Given this list of marker genes LGALS13, TGFB1, GPC1, PI3, IFNA17, P3H1, SFRP2 (NCBI Gene Id 6423), FGF22, WIF1, SERPINA5 (NCBI Gene Id 95024), SEMA6D, ADAM17, CLEC1A, SERPINB6, ADAM19, C1QL1, IL4, ANGPT2, BMP1, HBEGF, SERPINA11, ANXA6, LGALS9, FGFBP1, IL1F10, CTSS, CLEC1B, P4HA3 (prolyl 4-hydroxylase subunit alpha 3), C1QTNF3, IL1A, ELFN1, MMP3, P3H2, SERPINI2, IFNA10, SEMA3B, ADAMTS12, WNT8B, LOXL2 (lysyl oxidase like 2), GPC5, CLEC17A, FGF3, ITIH5, INHBB, C1QTNF9, S100A7A, INSL5, ITIH2, MMP28, ITIH4, S100P, CCL19, EPO, PDGFB, IFNA6, PLXDC2, EBI3, MMP20, SCUBE3, PRSS12, TIMP2, SFTA3, PLXNB3, ANXA7, ADAMTS13, CRNN, VEGFA, CXCL3, SDC3, TMPRSS15, IL13, ADAM7, MMP1, CST7, TLL1, BMP15, LEP, C1QTNF4, CLEC9A, IL36G, TCHH, CD209, CELA3B, S100A3 (S100 calcium binding protein A3), CTSC, C1QL4, PAMR1, OGFOD2, TGM1, IFNA8, LGALS14, MUC3A, CTSL, GDF10, EGLN1, ADAM28, ANGPT4, PZP, VEGFB, ADAMTS5, MSTN, IL22, SFTPC, A2ML1, CLEC4E, S100A7L2, FGF6, ADAMTS20, SERPINE3, SFRP1, CLEC10A (C-type lectin domain containing 10A), MMP24, SEMA3E, CLCF1, C1QTNF8, HTRA4, PDGFD, IL36RN, IL18, MMP10, PDGFA, TNFSF11, MUC19, PIK3IP1, ADAM10, PTN, C1QC, CBLN1, PLXNC1, SEMA4G, SERPINA10, F9 (NCBI Gene Id 14071), IL26, CLEC4G, LOX (lysyl oxidase), ANXA8L1, ITIH3, SEMA6C, FCN1, CBLN2, MMP21, CLEC4C, SERPINA9, DHH, TNFSF4, FRZB, CXCL11, TGM4, NTF4 (NCBI Gene Id 4909), ITIH1, P4HTM, TIMP4, FLT3LG, CXCL10, ADAMTSL1, ANGPTL3, IFNB1, S100B, TNFSF14, CCL14, PLAU, CLEC2B, ISM2, SEMA3D, WNT9A, HPSE, CLEC4A, ADAMTS8, ITLN2, S100A12, IFNA16, BMP4, C1QTNF7, IL9, SERPINB4, CRIPTO, WNT4, IL15 (NCBI Gene Id 3600), ELANE, NRG3, S100A5, GDNF, MMP11, GDF2, ADAMTS1, IFNW1, REG1A, ADAMTS15, VWC2, LGALS2, MUCL1, CD109, C1QB, CSF3, CLEC18C, TGM6, CCL24, LOXL3, IGF2, CLEC18A, S100A11, C1QTNF9B, MEP1A, CTSV, IL36A, ADAM29, PRSS2, BTC, ADAM20, SERPINA1 (NCBI Gene Id 5265), ADAMTS3, MUC21, CXCL14, C1QA (NCBI Gene Id 712), REG1B, TPO, ADAM33, ADAMTS9, CSHL1, IFNA13, IL1B, TIMP1, ELFN2, CHRDL2, C17orf58, FGF23, HYAL2, F2, SFTPA1, ADAMTS10, CNTF, IFNA7, IGF1, EGF, PSPN, ANGPTL2, ISM1, GDF7, LGALS16, SERPINE2, CLEC14A, CHRDL1, LGALS4, PARM1, NRTN, SEMA4D, PLAT, CSH1, CTSE, FGF18, SERPINF1, CCL20, MEGF11, ADAM23, WNT8A, NTF3, CLEC7A, CSPG4, IL37, S100A10, WNT5A, F13B, LMAN1L, EGFL7, MEP1B, IL25, FGF13, WNT7B, ADAMTS19, C1QTNF6, MMP15, S100A6, ANXA2, IL17B, MEGF8, GDF11, WNT9B (NCBI Gene Id 7484), MMP17, C1QTNF5, CLEC6A, LPA, FGF4, CSTL1, NRG2, CLEC12A, ADAMTSL4, SERPINB8, VEGFC, FREM3, MMP12, HCFC1, SEMA7A, PLOD1, ANXA4, WNT3A, MUC7, HABP2, WNT2, PCSK6, ITLN1, INHBC, IFNA21, HYAL1, CCBE1, TNFSF8, TGFA, INHA, GDF15, BMP8B, EGLN2, MMP25, MEGF10, IL16, ADAM18, CST11, LGALS9C, CLEC2L, ADAM12, FSTL1, GDF3, HGFAC, CTSO, ADAM21 (ADAM metallopeptidase domain 21), XCL1, ANGPTL1, SEMA3F, CXCL12, SFRP4, F12, CCL5, IL19 (NCBI Gene Id 29949), EREG (NCBI Gene Id 2069), FCN2, ANXA5, CCL22 (NCBI Gene Id 6367), IL1RN, WFIKKN2, SERPINA3, CCL15, TGM2, CLEC18B, S100G, SCUBE1 (signal peptide, CUB domain and EGF like domain containing 1), TNF, CTSG, SPAM1 (sperm adhesion molecule 1), SFTPD, ADAMTS2, FREM2, CST5, THPO, SERPINF2, BMP7, AGT, COLEC12, REG3A, ANGPTL4, S100A1, GH2, SERPINB11, CCL28, CLEC2D, CTSB, WNT6, SEMA3C, MMP9, TNFSF13, TGFB2, MUC20, ADAMTSL3, ADAMTS14, CELA1, ADAM11, IL5, CRLF1, FGF14, ADAM9, SERPINB3, GDF5, PCSK5, RPTN, ANGPT1, ZFP91, CCL3, SFRP5, S100A14, SDC2, SERPINA12, VWC2L, CXCL1, SDC4, CPN2, CCL4, LGALS8, CLEC4D, S100A9, CHRD, PLOD3, EPGN, CTSA, PLXNB2, CCL18, VEGFD, MASP1, CST9, FGF1, IL17A (interleukin 17A), HYAL3, IHH, F10, LGALSL, MST1, MEGF9, CELA3A, TNFSF15 (NCBI Gene Id 9966), CTF1, CFC1B, IFNA4, S100A13, HRNR, S100Z, IFNA1, KITLG, SERPINB2, IFNG, MUC17, SERPINA6, FAM20A, EGFL8, CFC1, SERPINB12, IFNA2, C1QTNF2, PPBP, ANGPTL7, WNT11, BMP6, SERPINB13, INHBA, REG4, HMSD, CX3CL1, MMP14, CST4, SERPINB10, CLEC19A, LEFTY1, CLEC2A (NCBI Gene Id 387836), HTRA1, INSL6, SEMA6A, MBL2, PLXNA3, FGF5, HYAL4, TLL2, ADAM15 (ADAM metallopeptidase domain 15), ANXA11, SERPINA7, CELA2B, CXCL8, A2M, FGF16 (NCBI Gene Id 8823), MMP26, AREG, FGF21, CTSW, SDC1, IL34, TNFSF10, CSF1, ANXA10, GPC6, ADAM32, F13A1, KY, IL23A, GREM1, CLEC12B, CTSH, IL12A, ARTN, CCL17, WFIKKN1, WNT10A, P3H3, C1QL3, CCL16, GDF6, MUC2, SFTPB, FGF8, EMCN, IL12B, IL11, HPSE2, CTSD, ADAMDEC1, IL2, MMP23B, HGF, ADAM2, TIMP3, CCL13, SEMA4C, PLXNA4, SLPI, CCL3L3, SERPINE1, EDA, FASLG, TCHHL1, IL17D, CCL23, CSH2, INS-IGF2, CCL8, S100A2, CTSZ (NCBI Gene Id 1522), SEMA4B, PRSS1, SERPINI1, PLXDC1, PF4V1, HCFC2 (NCBI Gene Id 29915), TGFB3, WNT3, ADAMTSL5, INS, ADAMTS18, CXCL6, PRL, TGM5, WNT5B, NRG4, HRG, FGFBP3, FGFBP2, ITIH6, WNT1, CLEC4M, AMH, SERPINA2, ANXA13, LGALS1, ANXA1 (NCBI Gene Id 301), MMP27 (NCBI Gene Id 64066), TNFSF18, ADAMTS6, GRIFIN, REG3G, GH1, SERPINB1, CBLN3, NODAL (NCBI Gene Id 8114), TNFSF13B, CLEC5A, CCL2, BMP3, ADAMTSL2, FGF7, MMP8, CST8, OVGP1, FST, KNG1, SCUBE2 (signal peptide, CUB domain and EGF like domain containing 2), IFNE, LMAN1 (lectin, mannose binding 1), C1QTNF1, WNT10B, P4HA1, LOXL4, CLEC4F, S100A4, MUC5AC, IFNK, CST6, IL36B, PLOD2, ADAMTS4, TNFSF12, CLEC3A, MUC15 (mucin 15, cell surface associated), MASP2, MUC12, CSTB (NCBI Gene Id 1476), IL17C, MMP2, S100A7, MUC22, CCL25, CLC, SEMA5A, LTA, NGF, FGF19, ANXA3, IL24, MMP16, CLEC3B, SHH, CRHBP, BRINP2, OPRPN, MDK, CCL26, P4HA2, MUC6, PF4, CSTA, PLXNA1, FGF9, CLEC11A, CST9L, CXCL13, ADAM22, MUC16, SEMA3A, TGM7, PLXNA2, HHIP, PRSS3, INHBE, SERPINC1, FGF17, IFNA14, IL3, FGF2, CCL11, BMP2, EGLN3, NRG1, SERPINB5, CCL27, SERPINA4, S100A16, MUC5B, CXCL2, IL17F, FLG, KAZALD1, HTRA3, ANGPTL5, LIF, BMP10, BDNF, CCL1 (C-C motif chemokine ligand 1), LGALS9B, S100A8, SULF1, MMP13, CTSF, GDF9, C1QL2, SULF2, ANGPTL6, WNT2B, FAM20B (FAM20B glycosaminoglycan xylosylkinase), PLXNB1, LGALS3, GPC2, PLXND1, INSL3, CCL7, SERPINB7, PLG, ANXA8, SFTPA2, CXCL9, LEFTY2, ADAMTS16, SEMA4F, CXCL5, IFNA5, SEMA6B, NGLY1, SFTA2, BRINP3, CELA2A, CST1, CTSK, ADAM30, AMBP, GDF1, ADAMTS17, OSM, MST1L, SERPING1 (serpin family G member 1), PAPPA, MUC1, HPX, CPAMD8, SEMA5B, OGFOD1, XCL2, GPC3, CCL4L2, SEMA3G, TGM3, SEMA4A, LGALS7, CST3, CSF2, MMP7, FSTL3, BMP8A, FCN3, FGF12, SERPINH1, SERPIND1, GPC4, IL10, FGF10, PGF, MEGF6, CSPG5, ST14, WNT7A, CCL21, IL6, PAPPA2, CBLN4, FGF20, CRLF3, TNFSF9, MMP19, FLG2, SERPINB9, LTB (lymphotoxin beta), LGALS12 (NCBI Gene Id 85329), EGFL6, ADAM8, WNT16, FREM1, MUC13, PDGFC, LOXL1, FAM20C, FGF11, ASTL, ANXA9, COLEC11, F7, IL20, ADAMTS7, IL7, MUC4, BMP5, CST2, COLEC10, here is a description of the gene set: Human Gene Set: NABA_MATRISOME_ASSOCIATED from publication Naba A, Clauser KR, Hoersch S, Liu H, Carr SA, Hynes RO (PMID 22159717) One hallmark of ECM proteins is their domain-based structure. Exploiting this characteristic, we established a list of diagnostic InterPro domains commonly found in ECM proteins. We know that some of the domains used to select positively for ECM proteins are also found in transmembrane receptors and proteins involved in cell adhesion (growth factor receptors, integrins, etc) that do not belong to the ECM. These families of proteins also display a subset of specific domains and transmembrane domains incompatible with definition as “extracellular matrix” proteins. Therefore, a second step comprised a negative selection using another set of domains and a transmembrane domain prediction. Manual curation of the matrisome lists also allowed us to add a very few known ECM proteins that do not contain any known domains. Protein-centric predictions were then converted to gene-centric lists. Finally, knowledge-based annotation of these gene lists allowed us to define subcategories within the core matrisome; namely, ECM glycoproteins, collagens, and proteoglycans. We also defined separate lists of domains commonly found in 1) ECM-affiliated proteins (proteins that share either some architectural similarities with ECM proteins or that are known to be associated with ECM proteins; 2) ECM regulators: ECM-remodeling enzymes, crosslinkers, proteases, regulators etc.; 3) secreted factors, many of which are known to bind to ECM and others that may. As for the core matrisome list, we also defined lists of domains that excluded mis-assigned proteins from these categories. Using similar bioinformatic pipelines as for the core matrisome, we defined three categories of “matrisome-associated” proteins: ECM-affiliated proteins, ECM regulators, and secreted factors. Ensemble of genes encoding ECM-associated proteins including ECM-affilaited proteins, ECM regulators and secreted factors studied in species Homo sapiens